The following is a description of a gene set: Any process that activates or increases the frequency, rate or extent of osteoclast development. Mouse Gene Set: GOBP_POSITIVE_REGULATION_OF_OSTEOCLAST_DEVELOPMENT species: Mus musculus, and this is the list of marker genes: Ninj1, Tnfsf11, Gpr68, Tyrobp, Slc9b2